The following is a description of a gene set: Mouse Gene Set: GOBP_PYRUVATE_METABOLIC_PROCESS The chemical reactions and pathways involving pyruvate, 2-oxopropanoate. studied in species Mus musculus, and this is the list of marker genes: Eno2, Gapdhrt2, Prxl2c, Galt, Myc, Nupr1, Hdac4, Ppara, Aldoc, Mpc2, Igf1, Hif1a, Tpk1, Pgam1, Mpi, Foxk1, Pfkfb2, Psen1, Pdk4, Lipa, Ier3, Mlxipl, Esrrb, Mtor, Bcl2l13, Pgk2, Pdk1, Arl2, Slc4a4, Enpp1, Jmjd8, Aldoart2, Slc16a3, Gpd1, Pcx, Me2, Hoga1, Ifng, Aldoa, Fbp1, Ins1, Eif6, Flcn, Rptor, Pdha2, Pfkm, Eno1, Hk1, Pck1, Pdha1, Ppargc1a, Kyat1, Aldob, Gpi1, Adpgk, Pgam2, Eno4, Tkfc, Pfkfb3, Aldoart1, Pdk2, Htt, Mpc1, Uchl1, Me3, Ddit4, Kat2b, Il3, Prkaca, Galk1, Dhtkd1, Prkaa2, P2rx7, Htr2a, Gapdh, Pgk1, Mfsd8, Hk3, Agxt, Pklr, Srr, Gale (galactose-4-epimerase, UDP), Mtch2, Tpi1, Eno3, Ldha, Slc16a1, Myog, Ppp2ca, Sds, Hkdc1, Stat3, Ogt, Mlx, Tigar, Src, Arnt, Ldhc, Pfkfb1, Ins2, Hk2, Prkag1, Ldhb, Insr, Bpgm, Vdac1, Gapdhs, Pfkp, Bckdk, Sirt6, Zbtb7a, Gapdhrt, Pdhx, Zbtb20, Sik2, Foxk2, Eno1b, Pdk3, Slc2a6, Fkrp, Slc4a1, Me1, Col6a1, Ep300, Prkag3, Ucp2, Gck, Ogdh, Pck2, Trex1, Dlat, Prkaa1, Actn3, Pdhb, App, Mlst8, Khk, Trim63, Prkag2, Ncor1, Pkm, Pfkl, Cbfa2t3, Dld, Ldhal6b, Git1